The following is a description of a gene set: studied in species Mus musculus Mouse Gene Set: GOMF_GAMMA_CATENIN_BINDING Binding to catenin complex gamma subunit., and this is the list of marker genes: Ptprj, Dsc3, Dsg1b, Cdh2, Cdh1, Ctnna1 (NCBI Gene Id 66546), Ptprk, Ptprt, Apc2, Dsg1c, Tcf7l2, Dsg1a, Lef1, Apc